Given this list of marker genes GNAI3, PLCB4, DHX30, FGFR2, STEEP1, TWIST1, ZNF462 (NCBI Gene Id 84452), TCTN3, HS2ST1, EDN1, NSD2, FGFR3, here is a description of the gene set: Abnormality of the crus of the helix studied in species Homo sapiens Human Gene Set: HP_ABNORMALITY_OF_THE_CRUS_OF_THE_HELIX An abnormality of the crus of the helix, which is the horizontal piece of cartilage located outside the ear canal that divides the upper and lower parts of the ear.